Given this list of marker genes PSMD6, PSMB3, PSMA2, PSMB4, PSMD12, PSMD2, MRC1, FCGR1A, PSMD1, SEM1, PSMC4, PSMB7, PSMD14, PSMC5, PSMD7, PSME1 (proteasome activator subunit 1), PSMC6, PSMA3, PSMD8, ADRM1, PSMB5, PSMB10, PSMA6, PSMA1, PSMA4, FCGR1BP (NCBI Gene Id 440607), PSMB6, PSMC1, CD207, PSMB1, PSMC3, PSMD11, PSMA7, PSMB8, PSMC2, PSMD13, PSMA5, PSMB2, PSMD3, MRC2, PSMB9, PSME2, here is a description of the gene set: studied in species Homo sapiens Reactome Pathway: Cross-presentation of soluble exogenous antigens (endosomes) Exogenous soluble antigens are cross-presented by dendritic cells, albeit with lower efficiency than for particulate substrates. Soluble antigens destined for cross-presentation are taken up by distinct endocytosis mechanisms which route them into stable early endosomes and then to the cytoplasm for proteasomal degradation and peptide loading. part of: Antigen processing-Cross presentation